The following is a description of a gene set: Genes having at least one occurrence of the motif NNANNGTAAACAANNN in the regions spanning 4 kb centered on their transcription starting sites. This matches the FOXF2 transcription factor binding site V$FREAC2_01 (v7.4 TRANSFAC). species: Homo sapiens Human Gene Set: FREAC2_01, and this is the list of marker genes: STK3, EN1, GNPNAT1, SZT2, LY86-AS1, AXL, ZNF362, IKZF4, TOB1, FOXB1, PELI2, CXXC5, NIPBL, CD109, FOXG1, DHX8, SCAMP1, POU3F3, PITPNC1, CALD1, DUSP1, C4orf19, BCAS3, BMP5, HIBADH, TET2, SCAF8, EGLN1, SLITRK5, CEP83, AKT2, AP1G2, NGEF, DSTN, DNAJB12, MED8, C12orf50, NAP1L3 (NCBI Gene Id 4675), FAM53C, HNF1A, BCL11A, POU3F4, SMAD5, BCL9, NDRG1, FOXP2, MRGPRF, NYAP1, KCNJ5, STOML3 (stomatin like 3), HAND2 (heart and neural crest derivatives expressed 2, NCBI Gene Id 9464), HEBP2, CPNE1, CPN1, CDX2, WIPI2, TSPAN8, ETV5, UHRF2 (ubiquitin like with PHD and ring finger domains 2), BDNF, ADAM12, CRCT1, PPP2R2B, SKIDA1, NRG1, ARID4A, RPS18, TPP2, IL25, SIN3A, EN2, MTTP, ELMO1, PHLPP1, MCM7, SYT1, ABTB1, AP4M1, ADAMTS13, TRPC4, DENND5A, BMP2, CGA (glycoprotein hormones, alpha polypeptide), FRY, SH3GL3, MMP13, RASGEF1B, CITED2, KLHL24, HOXA11, RASD1 (ras related dexamethasone induced 1, NCBI Gene Id 63428), ROR1, ASIC2, IGF1, IRS4, PAPPA, MORC1, BCL11B, KBTBD2, CLIP2 (CAP-Gly domain containing linker protein 2), HOXC4, DHRS3, FBXW7, BCLAF3, PCF11, CHCHD7, LINC03122, SCRN3, MITF, PAK1 (NCBI Gene Id 5058), PIK3C2A, MCC, MAP4K5, KCNQ5, PRKCH, TIAM1, PLAG1, SELENOP, FGF9, KLF3, PLCB2, DOCK3, LINC01101, MECOM, CHD2, RABGAP1L, E2F3, TXNDC12, IRAG1, DUSP4, PITX2, DTNA, EZH1, GREM1, JADE2, SQSTM1, GPR4, ID2, EMP1, HABP4, PLEKHA5, SKAP1, MID1, FGF12, MBNL2, PRDM1, RMND5A, HOXC8, VPS52, SYT6, FGF20, STOML2, PCDH18, NFIX, IKZF2, HIPK1, PTGR3, ERG, LIN54, PTCHD1 (patched domain containing 1), IL6ST, PTCH1, PDE7A, MARCKS, HBP1, CLPX, BPIFA1, GPRC5C, ZNF385B, TBX4, TCF15, PCSK1, HOXB4, SNX13, CLDN8, CFAP161, INHBA, THRA, LMO4, MLLT6, TXNIP, TFAP4, KDM6A, SCUBE3, UBE2H, CELF6, KY, MSMB, KMT2E, PPM1D, NFRKB (NCBI Gene Id 94689), EHBP1, CREBL2, ZNF521, FBXL22, SLC2A4, PROX1, RBM4, TGFB3, GPR174, MARCKSL1, MAB21L3, CDKN1C, ENPP2, VIT (vitrin), KCTD15, WEE1, FAM135B (family with sequence similarity 135 member B), RARA, SLC38A3, RTL9, HOXD9, RAD21, ZFHX3, C1orf43, LINC00173, RORA, NUDT18, ASCL4, CADM1, CD2AP, LMO3 (NCBI Gene Id 55885), EYA1, OFCC1, LRP5, BRAF, ZBTB18, CREBRF (NCBI Gene Id 153222), CDKN1A, FAM133A, SMAD1, TBCC, SERINC3, FOSL2, KLF12, KLF3-AS1, OTUD7B (OTU deubiquitinase 7B), PALS2, SLC34A3, NRAP (nebulin related anchoring protein), HR, PURA, ENOX1, MBNL1, HOXC12, SIAH3, EXT1, TAFA1, PLPP3, NTN5, ATXN1, MACO1, MAFF, NFIB, NNT, EPHB3, DSG4, CASC2, GPR137B, S100G, HHIP, ZFHX4, LINC00474, BRIP1